The following is a description of a gene set: Human Gene Set: GOBP_CENTROSOME_DUPLICATION The replication of a centrosome, a structure comprised of a pair of centrioles and peri-centriolar material from which a microtubule spindle apparatus is organized. species: Homo sapiens, and this is the list of marker genes: KAT2A, DEUP1, USP33, RAB6C, XRCC3, CHMP4C, ROCK2, MDM1, CHMP3, CHMP2B, PLK4, CEP44, OFD1, RBM14, PDCD6IP, TRIM37, CEP192, SAC3D1, PPP1R35, CEP63, CHMP1B, XPO1, PKHD1, POC5, CETN1, PKD2, BRCA1 (BRCA1 DNA repair associated), TMEM67, CDK5RAP2, PLK2, KAT2B, ARHGEF10 (Rho guanine nucleotide exchange factor 10), CCNF, CHORDC1, NDE1, CENATAC, VPS4B, CEP120, CDK2, CEP76 (NCBI Gene Id 79959), C2CD3, CHMP2A, NPM1, SIRT1, CEP295, WDR90, SASS6, CHMP5, NAT10, CENPJ, SPICE1, CNTROB, CHMP1A, NUBP1, CHMP4B, CCDC57, CEP72, POC1B, RTTN, POC1A, NUP62, BRCA2, CEP152, GEN1, STIL, CETN2, CEP295NL, ITGB1BP2, CEP85, CCP110, CKAP5, ALMS1 (NCBI Gene Id 7840), C10orf90, CEP135, BRSK1, NDC80, CEP131 (centrosomal protein 131), KIAA0753, CCDC15, FBXW5, WDR62